The following is a description of a gene set: Cytokines mediate cell-cell communication in the immune system and represent important therapeutic targets. A myriad of studies have highlighted their central role in immune function, yet we lack a global view of the cellular responses of each immune cell type to each cytokine. To address this gap, the authors created the Immune Dictionary, a compendium of single-cell transcriptomic profiles of more than 17 immune cell types in response to each of 86 cytokines (>1,400 cytokine-cell type combinations) in mouse lymph nodes in vivo. A cytokine-centric view of the dictionary revealed that most cytokines induce highly cell-type-specific responses. For example, the inflammatory cytokine interleukin-1β induces distinct gene programmes in almost every cell type. A cell-type-centric view of the dictionary identified more than 66 cytokine-driven cellular polarization states across immune cell types, including previously uncharacterized states such as an interleukin-18-induced polyfunctional natural killer cell state. Genes positively differentially expressed in cell type: B cell upon treatment with cytokine: IL-23 in mouse lymph nodes in vivo. from publication Cui A, Huang T, Li S, Ma A, Pérez JL, Sander C, Keskin DB, Wu CJ, Fraenkel E, Hacohen N (PMID 38057668) Mouse Gene Set: CUI_B_CELL_IL23_RESPONSE_UP species: Mus musculus, and this is the list of marker genes: Dlst, Ost4, H2-D1, Btg1, Notch2, Atp6ap1, Cirbp, Ms4a4c, Ms4a4b, Ankrd44, Mob4, Cd180, Cr1l, Aprt, Rbbp6, Map2k1, Cd47 (NCBI Gene Id 78539), Prdx6, Il10rb, Rnf144a, Rufy2 (RUN and FYVE domain-containing 2), Amn1, Avl9, Cd3d, Ralgps2, Washc3, Pou2f2, Saraf, Mir142hg, Ctss, Lactb, Tnrc18, Il21r, Dcaf8, Man2a1, Dapl1, H2-M3